Given this list of marker genes POLD4, NR2F2, TMSB4X, LGALS9, HSD17B2, COL6A1, TCN2, ALDOB, SLC12A2, TM4SF4, ABHD2, S100P, PFN1, VIPR1, GPA33, OLFM4, MSLN, FMO5, GLRX, PLEC, ST6GALNAC6, AKR1C3, CLU, FABP1, DMWD, FCGBP, ATP2A3, IGLL1, ITPK1, CA2, RALB, PGA5, REG1A, ISG20, DDX19B, ITGA3, FUCA1, LYN, RGS2, DAZ4, ACADS, PRSS22, ITGB4, BLOC1S6, CHGA, PCSK7, CCL15, MUC5B (NCBI Gene Id 727897), PXN, KDELR2, CCL14, WNT4, here is a description of the gene set: Human Gene Set: WANG_BARRETTS_ESOPHAGUS_UP studied in species Homo sapiens from publication Wang S, Zhan M, Yin J, Abraham JM, Mori Y, Sato F, Xu Y, Olaru A, Berki AT, Li H, Schulmann K, Kan T, Hamilton JP, Paun B, Yu MM, Jin Z, Cheng Y, Ito T, Mantzur C, Greenwald BD, Meltzer SJ (PMID 16449976) To investigate the relationship between Barrett's esophagus (BE) and esophageal adenocarcinoma (EAC), we determined gene expression profiles of discrete pathological stages of esophageal neoplasia using a sequence-verified human cDNA microarray. Fifty one RNAs, comprising 24 normal esophagi (NE), 18 BEs, and nine EACs were hybridized to cDNA microarrays. Five statistical analyses were used for the data analysis. Genes showing significantly different expression levels among the three sample groups were identified. Genes were grouped into functional categories based on the Gene Ontology Consortium. Surprisingly, the expression pattern of BE was significantly more similar to EAC than to NE, notwithstanding the known histopathologic differences between BE and EAC. The pattern of NE was clearly distinct from that of EAC. Thirty-six genes were the most differentially modulated, according to these microarray data, in BE-associated neoplastic progression. Twelve genes were significantly differentially expressed in cancer-associated BE's plus EAC (as a single combined tissue group) vs noncancer-associated BE's. These genes represent potential biomarkers to diagnose EAC at its early stages. Our results demonstrate that molecular events at the transcriptional level in BE are remarkably similar to BE's-associated adenocarcinoma of the esophagus. This finding alarmingly implies that BE is biologically closer to cancer than to normal esophagus, and that the cancer risk of BE is perhaps higher than we had imagined. These findings suggest that changes modulated at the molecular biologic level supervene earlier than histologic changes, and that BE is an early intermediate stage in the process of EAC. Genes up-regulated in Barrett's esophagus compared to the normal tissue.